Given this list of marker genes SAMTOR (NCBI Gene Id 154743), MAT2A, PRMT1, FUT1, NFE2L2, MTOR, here is a description of the gene set: species: Homo sapiens Human Gene Set: GOBP_RESPONSE_TO_METHIONINE Any process that results in a change in state or activity of a cell or an organism (in terms of movement, secretion, enzyme production, gene expression, etc.) as a result of a methionine stimulus.